Given this list of marker genes GPX1, PON1, ALOX5, GPX4, PON3, GPX2, ALOX5AP, LTC4S, PON2, here is a description of the gene set: part of: Arachidonate metabolism Reactome Pathway: Synthesis of 5-eicosatetraenoic acids species: Homo sapiens 5-hydroperoxy-eicosatetraenoic acid (5-HpETE), 5-hydroxyeicosatetraenoic acid (5S-HETE) and 5-oxo-eicosatetraenoic acid (5-oxoETE) are formed after the initial step of Arachidonate oxidation by arachidonate 5-lipoxygenase (ALOX5).